The following is a description of a gene set: from publication Chen Y, Wang X (PMID 31504780) Human Gene Set: MIR4299 species: Homo sapiens Genes predicted to be targets of miRBase v22 microRNA hsa-miR-4299 in miRDB v6.0 with MirTarget v4 prediction scores > 80 (high confidence targets)., and this is the list of marker genes: KMT5B, MAFA, CLIP1, BNC2, LZTS3, KLF11, L3MBTL3, TET1 (NCBI Gene Id 80312), PNP, FERMT2, DTD2 (NCBI Gene Id 338013), MORN4, ABHD4, ZNF773, ZNF781, ZBTB4 (NCBI Gene Id 57659), ZNF135, TFPI2, GGA3, KPNA4, CDCA2 (cell division cycle associated 2), PRDM7, CEP104, ARK2C, LSM14A, FJX1, CLVS1, CERT1, SLC22A23, PIK3R3, PPP1R16B, ZNF711, STAT5B, PDIK1L, SHISA7, RARA, RORB, MLF1, ENTPD7, MCTS1, ZNF268, ZKSCAN8, TMEM101, TAPT1, TMCC1, CWC25, MECP2, TRPS1, RALGAPB, PHYHIPL, CWC22, ZNF589, CREB1, ELK3, PLCXD3, SERP1, RBFOX2, IRAG1, THRB, HNRNPK, TAB3, ZGLP1, TIMM17A, COL25A1, BRIX1, ARL8B, DIO2, ZNF584, OSBP, GATA6, C2orf68, SHISA5, RBFOX1 (RNA binding fox-1 homolog 1), CYSLTR1, THBD, DCP1A